Given this list of marker genes Clic4, Arhgef15, Lrp5, Nrp1, Cyp1b1, Rhoj, Ndp, Col4a1, Slc4a7, Lama1, Fzd4, here is a description of the gene set: The process in which the vasculature of the retina is generated and organized. Mouse Gene Set: GOBP_RETINA_VASCULATURE_MORPHOGENESIS_IN_CAMERA_TYPE_EYE studied in species Mus musculus